Given this list of marker genes TJP1, TNMD, ICAM1, ID1, CLDN5, HPSE, RAP2B, HEG1, MSN, CDH5, RAPGEF3, CLDN1, F2RL1, FOXP3, ARHGEF26, FASN, ROCK2, SOX18 (SRY-box transcription factor 18), VCL, RAPGEF1, PDE2A, PECAM1, PPP1R12A, EDNRA, RAB1B, ROCK1, RDX, IKBKB, ZDHHC21, RAB1A, ADD1, STC1, COL18A1, PDE4D, MAGI1, AMOTL2, PROC, EZR, CLIC4, TJP2, PPP1R16B, EDNRB, TJP3, HOXA13, RAP2C, PTPRS, CLDN3, CCM2, F11R, ROBO4, TNFRSF1A, HAPLN2, RAPGEF6, MYADM, RAP1A, VEZF1, GSTM3, PLCB1, S1PR3, MARVELD2, PLOD3 (NCBI Gene Id 8985), RAPGEF2, MYD88, GPX1, RAP1B, IL1B, S1PR2, AFDN, TNF, NOTCH4, MET, VEGFA, here is a description of the gene set: studied in species Homo sapiens The progression of an endothelial cell over time, from its formation to the mature structure. Human Gene Set: GOBP_ENDOTHELIAL_CELL_DEVELOPMENT